Given this list of marker genes ENY2, TAF12, TRRAP, TAF10, KAT2A, TAF7, TAF6, TAF9B, TAF4, ATXN7L3, SUPT3H, TAF9, TADA3, TAF2, ATXN7 (NCBI Gene Id 6314), TAF5 (NCBI Gene Id 6877), TAF5L, USP22, here is a description of the gene set: studied in species Homo sapiens A protein complex that does not contain either a TATA-binding protein (TBP) or a TBP-like factor, but is composed of several TAFIIs and other proteins, including a histone acetyltransferase. This complex is able to nucleate transcription initiation by RNA polymerase II, can mediate transcriptional activation, and has histone acetyltransferase activity. Human Gene Set: GOCC_TRANSCRIPTION_FACTOR_TFTC_COMPLEX